The following is a description of a gene set: Human Gene Set: GSE26030_TH1_VS_TH17_DAY15_POST_POLARIZATION_UP Serial comparison between Th1 and Th17 tumor-specific cells cultured in vitro and ex vivo after transferred into sublethaly irradiated B6.PL mice. Th17-derived cells acquire Th1-like properties in vivo but maintain a distinct molecular profile. studied in species Homo sapiens from publication Muranski P, Borman ZA, Kerkar SP, Klebanoff CA, Ji Y, Sanchez-Perez L, Sukumar M, Reger RN, Yu Z, Kern SJ, Roychoudhuri R, Ferreyra GA, Shen W, Durum SK, Feigenbaum L, Palmer DC, Antony PA, Chan CC, Laurence A, Danner RL, Gattinoni L, Restifo NP (PMID 22177921) Genes up-regulated in T helper cells 15 days post polarization: Th1 versus Th17., and this is the list of marker genes: ASRGL1, GRIK5, NAA20, S100A10, MIR22HG, COL27A1, ALCAM, AFTPH, KCNIP4, RAB9A, INAVA, UBE2H, DAXX (death domain associated protein), LPIN1, ZC3HAV1, CEP97, SLC19A2 (NCBI Gene Id 7826), PLAC8L1, SEC22C, SENP7, LRRC19, TRIM46, PRNP, RDH12, FCRLA, GRB7, OARD1, ATF3, DUOXA2, NDC80, PLEKHF2, ABHD4, GJC1, MADD, ZMYM5, KDM7A, NSRP1, ATOSB, PRMT2, CNPY4, SLC35F5, CTSH, SCIN, CSF2RA, PDE7A, HEXB (NCBI Gene Id 3074), APOH, SELE, FRG1 (FSHD region gene 1), STK24, OTUD1, TUBA1A, RFC1, KCNH5, FAM8A1, TXNDC17, CTDSP2, PAX8, KCTD14, DNASE1L1, ALS2CL, LSS, HAPLN4, PRSS12, INPP5B, TRIM59, IFT25, APOLD1, TINF2, TCAF1, TIGD2, TRIP12, STARD4, PTTG1IP, PSMC2, DIPK1A, ACSS1, TCP11L2, HACL1, ATP6V0E2, UPF3A, SLC66A2, MAP3K9, PELI1, DNAJC28 (NCBI Gene Id 54943), AFF3, BCL2A1, RNASE6, FOXQ1, ZEB2, LGALS3, PEAR1, SH3GLB1 (SH3 domain containing GRB2 like, endophilin B1), ZBTB42, WNT2, VIPAS39, UQCRB, SLC25A20, CIB4, SAMHD1, BTNL9, CGAS, NATD1, CMAS, GRM7, RTP4, CSNK1G3, GOSR1, SIGLEC1, RAC1, SERINC5, SLC38A10, ZFAND3, CHMP4B, SIKE1, SEC62, EPGN, TOMM70, VIPR2, RP9, TPRG1L, RDH11, TMEM150C, FDFT1, AGPAT4, MXD1, ZNF277, SYNDIG1, PGGT1B, CARD6, AMIGO2, OSBPL9, HBP1, CD47, GPR155, IDH1, RMDN1, PHLPP2, IL2RA, PLPP2, IFNLR1, FRY, ODR4, MRPL1, HLA-E (NCBI Gene Id 3133), CTNNA1, CARHSP1, PHF21A, TENT5A, GPC6, THRA, PHF13, TYW1, GUCD1, WLS, TRIM25, FRYL, FAM3C, NT5C3A, CEP68, ATOSA, IL18, COPS3, CDK3, PLP2, KIT, SFTPB, TLR2, UFC1, CRYBG3, SMAP1, ZDHHC20, SYNE3, ADGRE1, ANKH, CDKN1B, PDCL3 (phosducin like 3), MICAL1, NR4A3, ACTR10, GNB4, TNRC18, TLCD1, NIBAN1, SLC39A4, TMEM92, PPP2R5C, CLIP3, APBA1, BBS4, RAPGEF4, SYNJ1, NPC2, ADAM19, SUB1, SLC35D2, UBE2D3, IL12B, TSC22D1